Given this list of marker genes PAX2, SLC26A5, COL11A1, PAX8, CDKN1B, TWIST1, USH1G, OTOP1, SOX9, MKS1, PTK7, EYA4, HPCA, FREM2, SPRY2, ADGRV1, GRXCR1, IFT88, NEUROG1, FZD6, COL2A1, DCHS1, DDR1, KCNK2, INSIG2, DLX6, BLOC1S5, ROR1, FGF8, SIX4 (NCBI Gene Id 51804), HOXA13, FGF2, TFAP2A, DVL2, USH1C, SEC24B, EPHB2, HESX1, CEP290, EDN1, CHRNA10, PLPPR4 (NCBI Gene Id 9890), SLC44A4, STOX1 (NCBI Gene Id 219736), ZEB1, CHRNA9, MYCN, BMPER, MPV17, DVL1, FZD3, SHH, IFT27 (intraflagellar transport 27, NCBI Gene Id 11020), LHX3, NIPBL, KCNQ1, FGF10, SLC25A27, NECTIN1, LRIG3, CECR2, ITGA8, CTHRC1, CLRN2, SLC4A7, GATA3, PLS1, MAPK1, AHI1, GLI3, ESRRB, TPRN, NAGLU, IGF1, HOXA1, TCAP, TBX2, NOX3 (NCBI Gene Id 57770), LIN7A, GABRA5, MAPKAPK2, SHROOM2, MINAR2, SOBP, NTN1, ZIC3, ALDH1A3, BMP4, TBX1, GSDME, NOG, DLX5, PI4KB, MAPK3, IFT20, CYTL1, NR4A3, OTX1, TECTA, STRA6, GRXCR2, MCM2, EDNRA, NEUROD1, DIAPH3, C1QTNF5, OTOL1, MYO6, ZIC1, SCRIB, GRHL3, PRRX1, VANGL2, RPGRIP1L, CCM2, LGR5, JAG2, ESRP1, GABRB2, PROX1, KCNK3, PCDH15, REST, NTRK3, SIX2, ATOH1, POU4F3, GBX2, LHFPL5, POU3F4, SLITRK6, FGFR1, HES1, HMX2, PJVK, HPN, ATG4B, ANKRD24, FOXG1, RAC1, EYA1, RPL38, TGFB2, BCR (BCR activator of RhoGEF and GTPase), FGF20, STRC, ATG5, ANP32B, NOTCH1, GSC, MYO3A, MAF, GET1, HMX3, CEBPA, JAG1, HEY2, PAFAH1B1, FGF9, TIFAB, CHD7, MYC, TMIE, ATP8A2, PDZD7, BMP5, MSX1, WHRN, WNT3A, WNT5A, TSHZ1, WNT1, MYCL, CDH23, WDR19, CCNA2, RBPJ, GATA2, INSIG1, SOX2, NHERF1, MYO3B, FRZB, TCF15, BCL2 (NCBI Gene Id 596), PHOX2B, CLRN1, BMP2, RDH10, ECE1, TBX3, OSR1, USH2A, TBX18, MCOLN3, CEBPD, DCANP1, ADAM10, OTOGL, PRKRA, OSR2, HES5, TTC39C, HOXA2, ATP8B1, MYO15A, GJB6, OC90, KCNQ4 (NCBI Gene Id 9132), TSKU, TRIP11, NKX3-2, TRIOBP, FGFR2 (fibroblast growth factor receptor 2), ELMOD3, BCL2L11, SLC17A8, MYO7A, CALB1, SDC4 (syndecan 4), WDPCP, SPARC, FZD2, EPHA4, TGFB1, FOXI1 (NCBI Gene Id 2299), DLL1, NECTIN3, SOD1, MAFB, PTPN11, SIX1, GABRB3, TTC8, TMC1, ATP6V1B1 (NCBI Gene Id 525), LRP10, LRIG1, here is a description of the gene set: Human Gene Set: GOBP_EAR_DEVELOPMENT The process whose specific outcome is the progression of the ear over time, from its formation to the mature structure. The ear is the sense organ in vertebrates that is specialized for the detection of sound, and the maintenance of balance. Includes the outer ear and middle ear, which collect and transmit sound waves; and the inner ear, which contains the organs of balance and (except in fish) hearing. Also includes the pinna, the visible part of the outer ear, present in some mammals. studied in species Homo sapiens